Given this list of marker genes Eps15, Wipi1, Kif16b (kinesin family member 16B), Ap1ar, Slc30a6, Ap4m1, Gbf1, Coro7, Dop1a, Sort1, Sys1, Klhl20, Rab14, Mon2, Dop1b, here is a description of the gene set: species: Mus musculus Mouse Gene Set: GOBP_GOLGI_TO_ENDOSOME_TRANSPORT The directed movement of substances from the Golgi to early sorting endosomes. Clathrin vesicles transport substances from the trans-Golgi to endosomes.